Given this list of marker genes Ripk3, Zbp1, Parp1, Aifm1, Trp53, Tspo, Ripk1, Casp6, here is a description of the gene set: Mouse Gene Set: GOBP_POSITIVE_REGULATION_OF_PROGRAMMED_NECROTIC_CELL_DEATH Any process that increases the frequency, rate or extent of programmed necrotic cell death. species: Mus musculus